Given this list of marker genes Icmt, Pcmt1, Lcmt1, Pcmtd2, Armt1, Lcmt2 (NCBI Gene Id 329504), Pcmtd1, here is a description of the gene set: species: Mus musculus Mouse Gene Set: GOMF_PROTEIN_CARBOXYL_O_METHYLTRANSFERASE_ACTIVITY Catalysis of the transfer of a methyl group to a carboxyl group on a protein.